The following is a description of a gene set: A process that identifies and degrades defective or aberrant mRNAs within the nucleus. Human Gene Set: GOBP_NUCLEAR_MRNA_SURVEILLANCE studied in species Homo sapiens, and this is the list of marker genes: DXO, XRN1, EXOSC5, ZCCHC7, EXOSC4, DIS3, EXOSC8, EXOSC10, EXOSC9, EXOSC6, EXOSC7